Given this list of marker genes CTBS, IFIT3, PLEKHO2, CLTB, CXCL1, H1-2, AQP9, S100A8, TALDO1 (transaldolase 1), TREM1, TYROBP, SECTM1, FCGR2A, VNN3P, CD58, SQOR, LITAF, TMEM140, SPATA2L, S100A12 (S100 calcium binding protein A12), C5AR1, ADGRE3, RALB, TMED1, MTHFS, NPL (N-acetylneuraminate pyruvate lyase), MME, DENND5A, QPCT, FTH1P5, RASSF2, CASP4, STX3, MCL1, CLC, USP10, LILRA2, ATP6V1B2, CAMP, MEGF9, ADAM8, ARAP3, ANXA3, SOD2, TNFRSF1B, ZNF185, KCNJ2, CFP, IER3, VNN2, CTSC, GAB2, BCL3, NDEL1, NUP214, PLXNC1, SORL1, ARHGEF40, IFITM2, CFD, S100P, NQO2, ADGRE2, NMI, NIBAN1, PPP4R1 (protein phosphatase 4 regulatory subunit 1), GIMAP4, FPR1, RAB5IF, TNFSF10, PLEK, KIAA0513, CKLF, ADGRG3, B4GALT5, CD300A, CXCR2, ZDHHC18, EFHD2, XKR8, PISD, S100A6, GK3, LST1, PTGS2, PILRA, IFITM1, EVI2A, CSF2RB, LY96, PLBD1 (phospholipase B domain containing 1), VASP, APOBEC3A, ID2, ADGRE5 (adhesion G protein-coupled receptor E5), MPPE1, PHC2, FGL2, AMPD2, SMIM27, CFLAR, CPPED1, IFITM3, TMBIM1, IFIT1, SLC31A2 (NCBI Gene Id 1318), ACAA1, MIR22HG, FCGR3B, HSPA1A, LAMP2, IFI6, SEC14L1, NCF2, TIMM8B, HLX, MAPKAPK3 (NCBI Gene Id 7867), NOP10, IMPA2, CEBPD, S1PR4, FRAT2, SRGN (NCBI Gene Id 5552), CD63, NRBF2 (NCBI Gene Id 91155), RNF130, LIMK2, CKAP4 (cytoskeleton associated protein 4), WAS, BIN2, BST1, RAB31, FLOT1, NDUFB3, MNDA, IGSF6, TRIB1, PPP2R5A, PPCDC, NAMPT, CLEC7A, FFAR2, TSEN34, PPT1 (palmitoyl-protein thioesterase 1), TXN, TNFRSF10C, NADK, FCN1, FRAT1, S100A11, CSF3R, NFE2, LILRB3, PYGL, CUEDC1, HCP5, MTX1, SLPI, ARPC5, MSRB1, CD302, ECE1, CXCL8, HCK, ACSL1, P2RY13, BID, TOR4A, HSPA6 (NCBI Gene Id 3310), ADM, BCORL1, CSTA, FAS, NHERF1, BCL2A1, RTN3, ABHD5, IMPDH1, NFIL3, GRIK5, SEMA4D, CXCR1 (C-X-C motif chemokine receptor 1), CYRIB, NINJ2, SERPINA1, S100A9, MYO1F, ITPK1, GCA, CLEC4A, ADAP1, FCER1G, SLC16A3, AIF1, IL1R2, APMAP, SH3GLB1, NINJ1, HCAR3, PRDX3, here is a description of the gene set: Human Gene Set: GSE22886_NAIVE_BCELL_VS_NEUTROPHIL_DN Genes down-regulated in comparison of naive B cells versus unstimulated neutrophils. from publication Abbas AR, Baldwin D, Ma Y, Ouyang W, Gurney A, Martin F, Fong S, van Lookeren Campagne M, Godowski P, Williams PM, Chan AC, Clark HF (PMID 15789058) Immune cell-specific expression is one indication of the importance of a gene's role in the immune response. In order to identify such patterns, we set out to broadly profile gene expression in a variety of immune cells. species: Homo sapiens